Given this list of marker genes Ubl4a, Rab5if, Sgta, Tmem147, Get4, Tmco1, Wdr83os, Ncln, Ccdc47, Bag6, Sgtb, Nomo1, here is a description of the gene set: A protein complex that is involved in the post-translational delivery of tail-anchored (TA) membrane proteins to the endoplasmic reticulum. TA membrane proteins, also called type II transmembrane proteins, contain a single C-terminal transmembrane region. Some ER membrane insertion complex subunits are conserved between different species such as mammals and budding yeast. Mouse Gene Set: GOCC_ER_MEMBRANE_INSERTION_COMPLEX species: Mus musculus